The following is a description of a gene set: Binds to and stops, prevents or reduces an ATP hydrolysis activity. Human Gene Set: GOMF_ATPASE_INHIBITOR_ACTIVITY studied in species Homo sapiens, and this is the list of marker genes: TSC1, HDAC6, FNIP1, PLN, FNIP2, ATP5IF1